The following is a description of a gene set: Genes from selected recurrently amplified regions in bone tissue tumors with supernumerary ring chromosomes. Human Gene Set: HEIDENBLAD_AMPLIFIED_IN_BONE_CANCER Ring chromosomes and/or giant marker chromosomes have been observed in a variety of human tumor types, but they are particularly common in a subgroup of mesenchymal tumors of low-grade or borderline malignancy. These rings and markers have been shown to contain amplified material predominantly from 12q13-15, but also sequences from other chromosomes. Such amplified sequences were mapped in detail by genome-wide array comparative genomic hybridization in ring-containing tumor samples from soft tissue (n = 15) and bone (n = 6), using tiling resolution microarrays, encompassing 32 433 bacterial artificial chromosome clones. The DNA copy number profiles revealed multiple amplification targets, in many cases highly discontinuous, leading to delineation of large numbers of very small amplicons. A total number of 356 (median size: 0.64 Mb) amplicons were seen in the soft tissue tumors and 90 (median size: 1.19 Mb) in the bone tumors. Notably, more than 40% of all amplicons in both soft tissue and bone tumors were mapped to chromosome 12, and at least one of the previously reported recurrent amplifications in 12q13.3-14.1 and 12q15.1, including SAS and CDK4, and MDM2, respectively, were present in 85% of the soft tissue tumors and in all of the bone tumors. Although chromosome 12 was the only chromosome displaying recurrent amplification in the bone tumors, the soft tissue tumors frequently showed recurrent amplicons mapping to other chromosomes, that is, 1p32, 1q23-24, 3p11-12, 6q24-25 and 20q11-12. Of particular interest, amplicons containing genes involved in the c-jun NH2-terminal kinase/mitogen-activated protein kinase pathway, that is, JUN in 1p32 and MAP3K7IP2 (TAB2) in 6q24-25, were found to be independently amplified in eight of 11 cases with 12q amplification, providing strong support for the notion that aberrant expression of this pathway is an important step in the dedifferentiation of liposarcomas. from publication Heidenblad M, Hallor KH, Staaf J, Jönsson G, Borg A, Höglund M, Mertens F, Mandahl N (PMID 16732325) species: Homo sapiens, and this is the list of marker genes: FGF23, TSPAN31, CCND2, CDK4, MDM2, FGF6, STK38L